Given this list of marker genes CBX5, SLFN5, MARS1, PFDN6, NOP2, NUP93 (nucleoporin 93), RBM14, JAKMIP2, NKX3-2, SERPINE2, NOP58, PARD6G, C8orf33, PSMA7, TEX2, GSTCD, NACC1, AREG, ATN1, ANTXR1, PSMD14, CWC15, RNF213, SND1, PML, CCDC6 (NCBI Gene Id 8030), BANF1, ENOPH1, ASB8, AURKA, LSM4, USP32, SLC25A14, RARS1, TSPAN9, MTHFD1, HMX2, TAPBP, EVX2, CDKN1A, DPF3, NXT1, NCAPD2, DCUN1D2, AMZ2, RPL24, CYP51A1, DUSP5, NUCB1, GCSH, PRR23A, EIF1B, TRAM2, C4BPA, NOP16, ATOX1, CRIPTO, CYB5B, MT1E, PSMD1, INF2, EIF2AK2, IRF2, ZNF467, FAM241A, IDH3A, BUB1, VPS53, LTA, AURKB, IRF7, CCDC102A, KCNS3, ASB13, TRIM5, RIGI, UBA7, OXCT1, FPR2, XCL1 (X-C motif chemokine ligand 1), SAAL1, DHX58, OLA1, AGPAT3 (NCBI Gene Id 83745), GMDS, TPH1, METTL8, PFN1, RSPH3, CAPN5, CCT8, TRMT112, F12, PUM3, IDNK, LHFPL6, RBMX, HSH2D, GIMAP4, PSMA3, POLE2, TAP2, STIP1, DCTN3, UTP15, GPI, ADSL, CTLA4, IGLL1, DOHH, REL, SHISA2, ADAM2, NSMCE2, DDX1, DAB2, TBRG1 (NCBI Gene Id 84897), OVOL2, CNP, RAC2, IGSF23, HIVEP3, TLR1, CASP7, RIC3, IDO1, FCN1, UNC80, DROSHA, SEC23B, CHMP4B, RNF19B, ICOS, STAT5A, AARS1, CST7, RAB38, MRPS16, NOP56, C3orf38, NIN, RNPEP (arginyl aminopeptidase), BUD31, RTCB, AGR3, STK39, UBE2C, RBP1, CASP8, MGAT4A, SCGB1A1, IL4R, TPO (thyroid peroxidase), FAM81A, ACAT2, SAMD9L, TAP1, METTL1, ALYREF (Aly/REF export factor), HSCB, DKKL1, TIMM50, ADAM19, PRKRA, CMPK2, ELMO2, ATP5MC3 (NCBI Gene Id 518), FDPS, SNRPF, DNMT1, ALG8, GART, SAR1A (NCBI Gene Id 56909), DMRTA1, ALDH1A2, MANSC1, HAT1, UQCR11, NT5E, RMDN3, MAPK9, IL22, NLRC5, UBL4A, GAS2L2, SCFD1, IL5, EMID1, ARRDC4, UPP1, ELOVL6, POMP, DCLRE1A, CIB1, CELSR1, IMMP2L, PTPRK, WDR48, MRPS10, EIF2B3, here is a description of the gene set: from publication Pearl JI, Lee AS, Leveson-Gower DB, Sun N, Ghosh Z, Lan F, Ransohoff J, Negrin RS, Davis MM, Wu JC (PMID 21362570) Genes up-regulated in comparison of untreated CD4 T cells versus CD4 T cells treated with leukocyte costimulatory blockade antibodies. Human Gene Set: GSE26669_CTRL_VS_COSTIM_BLOCK_MLR_CD4_TCELL_UP To elucidate the gene expression “footprint” of antigenically challenged T-cells which had been treated with anti-LFA-1, CTLA4Ig, anti-CD40-ligand antibodies, we performed microarray gene expression analysis comparing the expression profile of costimulatory blockade treated and untreated responder T-cells. studied in species Homo sapiens